The following is a description of a gene set: from publication Zheng Y, Josefowicz SZ, Kas A, Chu TT, Gavin MA, Rudensky AY (PMID 17237761) Transcription factor Foxp3 (forkhead box P3), restricted in its expression to a specialized regulatory CD4+ T-cell subset (T(R)) with a dedicated suppressor function, controls T(R) lineage development. In humans and mice, Foxp3 deficiency results in a paucity of T(R) cells and a fatal breach in immunological tolerance, causing highly aggressive multi-organ autoimmune pathology. Here, through genome-wide analysis combining chromatin immunoprecipitation with mouse genome tiling array profiling, we identify Foxp3 binding regions for approximately genes and for an intergenically encoded microRNA. We find that a large number of Foxp3-bound genes are up- or downregulated in Foxp3+ T cells, suggesting that Foxp3 acts as both a transcriptional activator and repressor. Foxp3-mediated regulation unique to the thymus affects, among others, genes encoding nuclear factors that control gene expression and chromatin remodelling. In contrast, Foxp3 target genes shared by the thymic and peripheral T(R) cells encode primarily plasma membrane proteins, as well as cell signalling proteins. Together, our studies suggest that distinct transcriptional sub-programmes implemented by Foxp3 establish T(R) lineage during differentiation and its proliferative and functional competence in the periphery. Human Gene Set: ZHENG_FOXP3_TARGETS_IN_THYMUS_DN species: Mus musculus Genes with promoters bound by FOXP3 and which are down-regulated only in developing (located in the thymus) regulatory CD4+ T lymphocytes., and this is the list of marker genes: APH1A, AMPH, EPB41, PRSS2, ADIPOQ, MAP4K4, AKR1D1, CADPS, AGR2, ZBED3, TUBE1, NR4A2